The following is a description of a gene set: Human Gene Set: GOBP_NEGATIVE_REGULATION_OF_INSULIN_LIKE_GROWTH_FACTOR_RECEPTOR_SIGNALING_PATHWAY Any process that stops, prevents, or reduces the frequency, rate or extent of insulin-like growth factor receptor signaling. studied in species Homo sapiens, and this is the list of marker genes: MIR1-1, CILP, BMP5, ATXN1, IGFBP5, MIR29C, TRIM72, BMP2, INPPL1, NKX3-1